Given this list of marker genes TWNK, PLEKHG5, TYMP, MFN2, HK1, PRX, PNPT1, SH3TC2, HSPB8, NEFL, APTX, GDAP1 (NCBI Gene Id 54332), LMNA, SACS, SPTLC1, LIG3, RRM2B, ELP1, MME, POLG, here is a description of the gene set: studied in species Homo sapiens Human Gene Set: HP_DECREASED_NUMBER_OF_LARGE_PERIPHERAL_MYELINATED_NERVE_FIBERS A reduced number of large myelinated nerve fibers. Decreased number of large peripheral myelinated nerve fibers